The following is a description of a gene set: Mouse Gene Set: GOBP_POSITIVE_REGULATION_OF_INFLAMMASOME_MEDIATED_SIGNALING_PATHWAY Any process that activates or increases the frequency, rate or extent of an inflammasome-mediated signaling pathway. species: Mus musculus, and this is the list of marker genes: Cd36, Lats2, Casp4, Gbp2, P2rx7, Gbp5, Tlr4, Brcc3dc, Nek7 (NIMA (never in mitosis gene a)-related expressed kinase 7), Stmp1, Mapk8, Ddx3x, Lats1, Zdhhc5, Zdhhc1, Gm12250, Mavs, Ppp2ca, Usp50, Brcc3, Atat1, Prkd1, Btk, Tlr6, Ptpn22, Dhx33, Plcg2, Mark4, Myd88